Given this list of marker genes Tmod4, Lmod1, Tmod1, Lmod3, Tmod2, Tmod3, Lmod2, here is a description of the gene set: Mouse Gene Set: GOBP_POINTED_END_ACTIN_FILAMENT_CAPPING The binding of a protein or protein complex to the pointed (or minus) end of an actin filament, thus preventing the addition, exchange or removal of further actin subunits. studied in species Mus musculus